Given this list of marker genes Ercc3, Ercc8, Ercc2, Uvssa, Polr2i, Ercc6, Hmgn1, Ercc5, Xab2, Usp7, here is a description of the gene set: studied in species Mus musculus Mouse Gene Set: GOBP_TRANSCRIPTION_COUPLED_NUCLEOTIDE_EXCISION_REPAIR The nucleotide-excision repair process that carries out preferential repair of DNA lesions on the actively transcribed strand of the DNA duplex. In addition, the transcription-coupled nucleotide-excision repair pathway is required for the recognition and repair of a small subset of lesions that are not recognized by the global genome nucleotide excision repair pathway.